The following is a description of a gene set: species: Homo sapiens from publication Chen Y, Wang X (PMID 31504780) Genes predicted to be targets of miRBase v22 microRNA hsa-miR-548p in miRDB v6.0 with MirTarget v4 prediction scores > 80 (high confidence targets). Human Gene Set: MIR548P, and this is the list of marker genes: FBXL17, SNAP29, MYO1H, RHOQ, GAS2 (NCBI Gene Id 2620), NR4A3, CXCL5, SCLT1, ABHD17C, BTRC, SMARCAD1, CHMP2B, MST1L, SORBS2, PTER, KCNT2, HELZ, DEPDC4, EVI5, MYT1L, IL20, UQCRB, NCOA3, RO60, ALG6, EPB41L4B, BORCS7, B3GALT1, YAP1 (Yes1 associated transcriptional regulator), SERTAD2, ZNF704, NAV1, ZFP36L1, KMT5B, KICS2, C7orf57, SPON1, NRIP1, TRPM8, SRSF6, EIF4E, LAMP1, CHL1, ZNF107, LRATD2 (NCBI Gene Id 157638), FNDC3B, ATP6V0A2, C1GALT1C1, C2orf42, TGIF2, SCNN1G, RPS6KA6, PIAS2, PJA2, PRORP, ZC3H12C, GABRR2, CNIH4, HSPA1B, STK4, IRS2, BBX, OSMR, PSD3, PLXNA1, CSDE1, USP9X, SVEP1, TAFA4, GABRB2, TIMP3, SWAP70, MFAP3L (microfibril associated protein 3 like), SLC16A10 (solute carrier family 16 member 10), GABRB3, ZC2HC1C, ZNF699, GPBP1, FNIP2, ACKR4, VEGFA, FGFR1, MAP1B, MBTD1, ZCCHC3, MFAP1, TBL1XR1, SKIL, PROM2, SBNO1, ARL5B, B3GNT5, ITPRIPL2, ZEB2, TSC1, FSD1L, MAST4 (NCBI Gene Id 375449), IP6K2, KLF6, KLHL11, JAM3, CPEB2, RBMS1, FGFR2, ARHGAP24, SLC16A9, CAPRIN1, PLS3, HMGB2, FAM171A1, SYNPO2, CACNA2D1, BTBD8, KPNA1, SCN3A, UNC5C, CDK6, KCTD4, APOB, SOX6, PTAR1, SANBR, SYNJ2BP, TMEM185A, SUPT7L, ARL8A, PKN2, POLB, USP15, ABL2, CD1A, GSKIP, VAV3, LRP6, HEPACAM2, AAK1, EDIL3, LMO3, NAP1L5, CNIH1, BMAL2, DIAPH1 (diaphanous related formin 1), HACE1, ZNF664, TAF4, VGF, KIF20B, IQCJ-SCHIP1, MTCL3, PABIR2, CD302, DCAF16, PDCD10, GPM6B, ARMC8, KCNQ5, TIAL1, IRF2BP2, DNMT3B, KDM7A (NCBI Gene Id 80853), PRRG1, FBXO4, GABRA1, CADPS, CEP15, CD9, PPM1A, TBCC, SLC19A2, ETV1, TRIM66, PXK, ZFHX4, ATP8A1 (ATPase phospholipid transporting 8A1), CDH11, EZR, MOSMO, CTCF, LEF1, KMT2E, SYTL4, FBXO30, SAMTOR, ZKSCAN1 (zinc finger with KRAB and SCAN domains 1), TTC28, SECISBP2L, SEMA3E, EPPIN, EXOC5, VSNL1, RAB31, MT1G, CAPS2, CHFR, BMPER, SUDS3, PIK3R4, SYNM, DPY19L1, THUMPD1, PDE7B, PGM3, LY75-CD302, REV3L, KLHL15, ZNF597, ZDHHC13 (zinc finger DHHC-type palmitoyltransferase 13), THBS1, CTLA4, SRSF1, SMIM13, MAP7D2, SOCS2, ZNF148, DCUN1D4, CHODL, TSPYL5, PARG, MPZL3, PAPOLA, TNPO1, IGSF10 (NCBI Gene Id 285313), RAB18, NUP205, MAN1C1, TLCD5, OTUD4, MRAP2, MIGA1, PGGT1B, RORA, AGPAT3, NSD2, TRIM23, EPHA7, GLRA2, C8orf44-SGK3, RBBP5, UBR5, SLAIN1, AP1S2, SPCS2, QKI (NCBI Gene Id 9444), IL33, PPARD, MIPOL1, OSBPL1A, MAP3K20, E2F7, TMEM26, CNN3, RMND5A, MRPL42, AGFG1, PITPNC1, RAPH1, OGFRL1, ARHGEF26, SLC16A6, DGAT2, SMARCC1, SEC22A, STYX, TLCD4, PCDH19, RAB11FIP2, ZNF300, LNX2, MAML1, CALHM4, PNRC1, ZBTB21, RRAS2, ISX, CHM, TRIM2, WDFY3, MTF1 (metal regulatory transcription factor 1), CBLN1, ZNF407, CDK12, RAB21, CCND2, DNAH14, INO80D, B4GALT6, EFR3A, DSG2, PPP3CA, ZMYND12, CLEC3A, IRF2BPL, RNF141, SLC38A1, RAB40B (RAB40B, member RAS oncogene family), STIM1, UHMK1, PCF11, TRAM1, PLAGL2, GTF2A1, ARPP21, SURF4, STXBP5L, PMP22, TIAM1, METTL14, LATS2, ZNF518B, SRPK2, PIM2, OSBPL3, SLC38A4, DNAJB6, CEBPA, STXBP6, TC2N, ACER3, STXBP5, GABRA2, ZNF570, PBX1, OSBPL6, THAP11, HSPH1, TSGA10, ZNF813, NHSL1, ACBD7, ETNK1, CACUL1 (CDK2 associated cullin domain 1), COMMD2, CLINT1, FLT3, NEUROD4, CORO1C, EAF1, CNTN4, TCF21, VNN1, GLYR1, LSM8, VKORC1L1, CREBRF, VPS26A, YWHAZ, FAR1, MAP2, FOXN2, ZNF740, FAT3, CELF2, TOB2, AKAP11, AGO4, RNLS, SOWAHA, CLEC4E, SMPDL3A, CTTNBP2, ZNF143, KIAA0408, CLU, ANKRD63, CPNE4, SPG21, MECP2, PBLD, CSNK1D, RABL3, NANOS1, MYOG, SEC23A, UBQLN2 (NCBI Gene Id 29978), SLC36A4, SLC2A13, MATN3, BAAT, GUCY1A2, NGDN, SLC9A9, SOAT1 (sterol O-acyltransferase 1), ELOC, RB1 (RB transcriptional corepressor 1), CYFIP2, MSI2, TLR5, TBC1D9, SCG5, RAB9B, CBLB, TP53INP1, ZBTB44, THSD7A, KMT5A, NBR1, ASB15 (NCBI Gene Id 142685), ERBIN, FSTL5, ZMAT3, EIF1AX, PRKAR1A, API5 (NCBI Gene Id 95494), WASF1, FBXW11, CAP2, SV2C, HIPK3 (NCBI Gene Id 10114), SH3KBP1, CPEB3, KTI12, DTWD1, GPR12, TDRD6, KIF5B, RRP15, CNBP, RNF19A, SCD5, MMP16, SERINC5 (NCBI Gene Id 256987), PIP4P2 (phosphatidylinositol-4,5-bisphosphate 4-phosphatase 2), ISY1, ZC3H13, IPPK, H1-0, TRA2A, KPNA4, NECAP2, DCLRE1C, DEFB129, PLIN1, PCDH18, PRKCA, PHLDA1, CCDC115, TOP1, STRAP, F13A1, SEPTIN11, NUFIP2, FUNDC2, ZBTB6, LRP1B, FBN2, RUFY1, DESI2, SP1, TBX18, PRKG1, ALDH1L2, VPS13B, CLCN4, PDE6H, RNF41, TNKS, THAP2, NKD1, SLCO2A1, COL25A1, PEAK1, ZBTB43, AHR, USP31, FKTN, KDSR, TMEM64 (transmembrane protein 64), LONRF1, CADM2, YBX3, UBAP1, RNF24, TMEM30A, NF1, TPK1, JUND (NCBI Gene Id 3727), AP3B1, DSP, RICTOR, NFKBIZ (NCBI Gene Id 64332), DUT, SRSF4, SEMA3A, PIGA, UBP1, KIF13A, ACTL6A, ENC1, NOX4, KCNN3, SGK3, BRWD3, TNIP1, RAB5B, RNPS1, STK35, PAIP1, C18orf63, SPAG16, DEPDC1 (DEP domain containing 1), SFT2D1, AFTPH, IGSF3, SMIM14, ASB3, SEL1L, PCGF5, SLC35E4, ZDBF2, SUV39H2, PDE3A, SLC7A7, EREG, CHN2, SCAI, PIK3R1, PDE4D, MAF, ADAMTS6 (ADAM metallopeptidase with thrombospondin type 1 motif 6), MBD2, ABCC5, MAPK8, PKD2L2, IL22RA2, PHF3, SLC36A2, NRBP1, AMMECR1, CLASP1, SLC1A2, TSHZ3, TMX3, SH2B3, VTI1A, FAM98A, ZDHHC21, LACTB2, CYP39A1, LRP1, MEIS2, RFFL, LCLAT1, G6PC1, PLXDC2, PSMD4, CPA4, NFXL1, SYBU, RAB8B, PRELID3B, KCNV1, APOL6, ARL13B, TAOK1, FAM135A, HAUS2, EXOSC1, ZKSCAN4, STRN3, CYP26B1, MACF1, ZFX, GATA2, NFAT5 (nuclear factor of activated T cells 5), CCP110, MAFB, GRIA4, GAS7, LIN7C, PLCH1, TOB1, RAPGEF6, PHC3, CNTNAP2, GALNT16, FOXP1, FMNL2, MIER1, SPOPL, CTTNBP2NL, ADAM10, NAP1L4, RC3H1, WTAP, LBR, SLC7A1, CHRDL1, SCP2, PHIP, ARL6IP6, CSRNP3, LRRN1, ING2 (NCBI Gene Id 3622), GOPC, ATAD2B, ZCCHC8, CEBPZOS, SIPA1L2, MIS18BP1 (NCBI Gene Id 55320), PLCB4